The following is a description of a gene set: Genes that are most strongly negatively correlated with systolic blood pressure (SBP). from publication Petretto E, Sarwar R, Grieve I, Lu H, Kumaran MK, Muckett PJ, Mangion J, Schroen B, Benson M, Punjabi PP, Prasad SK, Pennell DJ, Kiesewetter C, Tasheva ES, Corpuz LM, Webb MD, Conrad GW, Kurtz TW, Kren V, Fischer J, Hubner N, Pinto YM, Pravenec M, Aitman TJ, Cook SA (PMID 18443592) Left ventricular mass (LVM) and cardiac gene expression are complex traits regulated by factors both intrinsic and extrinsic to the heart. To dissect the major determinants of LVM, we combined expression quantitative trait locus1 and quantitative trait transcript (QTT) analyses of the cardiac transcriptome in the rat. Using these methods and in vitro functional assays, we identified osteoglycin (Ogn) as a major candidate regulator of rat LVM, with increased Ogn protein expression associated with elevated LVM. We also applied genome-wide QTT analysis to the human heart and observed that, out of 22,000 transcripts, OGN transcript abundance had the highest correlation with LVM. We further confirmed a role for Ogn in the in vivo regulation of LVM in Ogn knockout mice. Taken together, these data implicate Ogn as a key regulator of LVM in rats, mice and humans, and suggest that Ogn modifies the hypertrophic response to extrinsic factors such as hypertension and aortic stenosis. Human Gene Set: PETRETTO_BLOOD_PRESSURE_DN species: Rattus norvegicus, and this is the list of marker genes: QSER1 (NCBI Gene Id 79832), HSD3B1, XRCC4, RBM8A, FBXL3, CX3CR1 (NCBI Gene Id 2836), KDM5B (lysine demethylase 5B), CYTH2, CEBPG